The following is a description of a gene set: Normal human diploid fibroblasts (HDFs) are refractory to oncogene-mediated transformations in vitro, compared with rodent fibroblasts. As successful oncogene-mediated transformations of normal HDFs have been reported using the human telomerase catalytic subunit, it has been considered that telomerase activity contributes to the species-specific transformability. However, these transformed HDFs are much less malignant compared with those of rodent cells, suggesting the existence of undefined mechanisms that render HDFs resistant to malignant transformation. Here, cDNA microarray analysis identified caveolin-1 as one of the possible cellular factors involved in such mechanisms. The mitogen-activated protein kinases (MAPK) pathway downregulates Caveolin-1 in rodent fibroblasts, transformed by coexpression of the SV40 early region and activated H-Ras. In contrast, the coexpression of these two oncogenes in HDFs failed to reduce the expression level of Caveolin-1. These results strongly suggest the presence of critical differences in events following the phosphorylation of ERK during the activation process of the MAPK signaling pathway between human and rodent cells, as the ERK protein was similarly phosphorylated in both systems. Furthermore, the small interfering RNA-mediated suppression of Caveolin-1 facilitated the oncogene-mediated transformation of normal HDFs, clearly indicating that the differences in the transformability between human and rodent cells are due, at least in part, to the mechanism responsible for the resistance to Ras-induced Caveolin-1 downregulation in HDFs. studied in species Mus musculus Mouse Gene Set: SASAI_RESISTANCE_TO_NEOPLASTIC_TRANSFROMATION Genes down-regulated in MEF and REF cells (mouse and rat fibroblasts) but not in TIG3/T cells (human lung fibroblasts expressing TERT) by co-expression of the SV40 early region and the activated HRAS (H-RasV12). from publication Sasai K, Kakumoto K, Hanafusa H, Akagi T (PMID 16832346), and this is the list of marker genes: Sdc2, Ltbp2, Col1a1 (collagen, type I, alpha 1), Abcb6, Fbln5, Id3, Tagln, Il1rl1, Selenop, Vldlr, Gjb3, Mmp11, Cebpd, Edn1, Atp1b1, Tnfrsf11b, Qsox1 (quiescin Q6 sulfhydryl oxidase 1), Gbp2, Csrp1, Id4, Cdkn2c, Slc16a7, Amotl2, Irf1, Tnfrsf1a, Fbn1, App, Cxcl12, Adamts1, Junb, Cacnb3, Fbln2, Tgfb3, Col5a2, Pcolce, Ccn2, Il6st, Rgs10, P3h1, Fstl1, Pdgfrb, Ddr1, Ifngr1, Ccn5, St3gal5, Bgn, Lamb2, Col5a3, Plod2, Tgfb1i1